Given this list of marker genes POLB, AKT3, PSMA4, NUDT13, MAN2A1, MICAL2, CUBN, DTX1, NAT1 (N-acetyltransferase 1), COL14A1, AKAP12, HOOK2, AMDHD1, RASA3, IRF8, CEMIP, ITGB7, CTSG, CDYL, NRBP1, CSNK1D, USF1, MICU1, NRDE2, PTGDR2, ST14, USP15, WNK2, DIO2, TIFA, GUCD1, SCNM1, PLEKHS1, GRIK5, ANPEP, PLEKHN1, CASP7, PCMTD1, REL, KIF3A, DNTTIP1, KIAA1143, LYRM1, ADISSP, PHGDH, GATA4, SV2A, NCK1, NFIA, UBE2J2, CPTP, SYNGR1, EFNA4, TUBA8, WNK1, LAT2, BHLHE41, TBK1, C19orf25, MSANTD2, ITM2C, PLXDC2, PLEKHO2, BIRC2, PEAK1, TIMP2, STAT4, TMEM53, FBXO16, STX4, KIF11, CD300A, IDNK, TMEM50B, CBLC (NCBI Gene Id 23624), TLE2, SNX4, CLN8, HDAC1 (NCBI Gene Id 3065), FHDC1, EPB41L2, ABCG1, SLC12A9, IGBP1, CES4A, TAB2, NDRG2, KCNN2, IFFO2, CHRD, PMF1, STK24, NES, TBL1X, PCCA, DNPEP, CDC42EP4, COL1A2, SMC5, TMOD3, NTS, PPP1R11, SELPLG, GTF2F1, IL33, TANGO2, MLF2, AP3B1, PPDPF, COX18, PRKX, HSCB, UTP3, SAT1, NUDT9, SFN, SH3RF1, APOD, SPDL1, ZIM3, ANKFY1, ENG, PLEKHA2, SLC9A1, TNFRSF12A, IL2RG, ICAM2, ZNHIT1, KYNU, CCL19, GALNT16, VGLL4, PURG, CTSC, SPINT2, CCNL1, UBE2B, AQP3, SEPTIN10, IL10RA, PSME2, PFKFB3, USP47, ASB11, SEH1L, CST3, LACTB, GNAZ, NQO2 (N-ribosyldihydronicotinamide:quinone dehydrogenase 2), UBL7, ARL4C, LARP1, TLR9 (toll like receptor 9), PLEKHF2, TFG, ARL4A, RIPK1, APOOL, TRIP10, SORL1, STX8, LIN37, KDM3B (NCBI Gene Id 51780), OCIAD1, PCYT1A, CEACAM21, BCL9, ATAD1, TP53INP1, PCMT1, TH, ARF6, LRRC8C, PKLR, SLC41A3, CIPC, NFKBIB, CERT1, C6orf62, PIGO, RNH1, IL2RA, MED12, PPP4R1, RB1CC1, MAPRE2, IGFBPL1, EAPP, PSMB6, NASP, NKD2, ATP6V0A2, DNASE2, NLGN2, RNF167, GHR, CDKN1A, SLC15A4, AVL9, FZR1, here is a description of the gene set: mouse primary BMDCs were stimulated with tlr ligands and gene expression changes were profiled on Affymetrix arrays from publication Amit I, Garber M, Chevrier N, Leite AP, Donner Y, Eisenhaure T, Guttman M, Grenier JK, Li W, Zuk O, Schubert LA, Birditt B, Shay T, Goren A, Zhang X, Smith Z, Deering R, McDonald RC, Cabili M, Bernstein BE, Rinn JL, Meissner A, Root DE, Hacohen N, Regev A (PMID 19729616) Genes up-regulated in comparison of dendritic cells (DC) stimulated with poly(I:C) (TLR3 agonist) at 12 h versus DC cells stimulated with Pam3Csk4 (TLR1/2 agonist) at 12 h. species: Homo sapiens Human Gene Set: GSE17721_POLYIC_VS_PAM3CSK4_12H_BMDC_UP